Given this list of marker genes SLC7A6, SLC7A5, SLC43A1, SLC25A44, SLC43A2, LLGL2, SLC6A14, SLC6A20, SLC38A9, SLC3A2, SLC7A7, SLC6A17, SLC7A8, SLC6A15, here is a description of the gene set: species: Homo sapiens The directed movement of branched-chain amino acids into, out of or within a cell, or between cells, by means of some agent such as a transporter or pore. Branched-chain amino acids are amino acids with a branched carbon skeleton without rings. Human Gene Set: GOBP_BRANCHED_CHAIN_AMINO_ACID_TRANSPORT